The following is a description of a gene set: from publication Chen Y, Wang X (PMID 31504780) Human Gene Set: MIR561_3P studied in species Homo sapiens Genes predicted to be targets of miRBase v22 microRNA hsa-miR-561-3p in miRDB v6.0 with MirTarget v4 prediction scores > 80 (high confidence targets)., and this is the list of marker genes: BAIAP2, MGAT5, TVP23C, DNAJC7, NCL, NR1D2, EYA4, CPEB4, RNF141, SEPTIN7, C1QTNF3, DSG1, AMBN, ZNF471, CCL4, ZNF148, PIAS2, INO80D, UBE2K, SERINC5, PAK2, PEX5L, PRKRA, LRP12, ABHD13, DYRK4, LRRK2, EDIL3, PTGER3, REEP5, PSD3, PBX1 (PBX homeobox 1), FGF9, ARHGEF12 (Rho guanine nucleotide exchange factor 12), ECT2L, UBR3, STXBP5, MTMR7, KRR1, LMX1A, CGGBP1, GMCL1, APC, KRTAP4-7, RPS6KA6, VPS37A, ZBTB18, YPEL5, WDR43, GLS2, ZBTB1, ELAPOR2, SPAG9, SERF1A, TRIM2, DAZL, MYL12A, ARHGAP11A, TRUB1, PPM1N, HSD11B1, PCNX4, TLR2, PDSS1, DPY19L3, USP15, PRKD3 (protein kinase D3), NUCKS1, UNC119, TPM3, FZD1, SLC25A53, QKI, GADD45G, ADGRE2, VMP1, ZEB2, TEX14, ADGRL2, ADGRB3, SDC1, PBX3, RORA, UBE2W, MAML2, ZBTB21, PKD2 (NCBI Gene Id 5311), TENM4, OPRM1 (NCBI Gene Id 4988), LRRTM3, GRIA2, UBE2H, SLC18A2, SCAP, PRRG4, IRS2, KRTAP3-1, USP44, PHF6, TRIM13, MICU3, DNM3, STC1 (NCBI Gene Id 82914), CFAP61, SAMD12, PPA2, MARF1, WIPF3, DLGAP1, EPHA7, ZNF768, BCLAF3, GNPAT, SLC4A4, CAAP1, MOSPD1, CUL2, APOL6 (apolipoprotein L6), CLEC2B, QNG1, GPR63, ZNF816, PTPN21, EHBP1, HMG20A, PLAT, FAM124A, N4BP2L2, ATP8A1, TIGAR, RP2, FGF12, ABCA5, IWS1, NKX3-2, MIB1, ERV3-1, PCNX1, SLC45A4, MAGT1, DAZ2, PTPMT1, PCDH11X, ALG10B, PRPF40A, LRRC10, ARRDC3, IPCEF1, SOX2, SAMTOR, NIN, MAK16, NBN, ZBTB43, SETD9, ZNF280D, ARL8B, PPP4R2, SMARCA5, NETO2, ODF2L, KLF8, CORIN, RETREG1, CCL4L2, DDHD1, UFL1, GHR, HACD2, ACP3, CACNA1B, RO60, ATF7IP (NCBI Gene Id 55729), MBNL2, MZT1, ARMC3, ZFHX3, ZYG11B, CARF, MED14, C1orf21, CDH19 (cadherin 19), CNTN1, RFX3, GALNT2 (polypeptide N-acetylgalactosaminyltransferase 2), SFT2D1, CDK6, COL19A1, OMG, CEP55, TAF10, GTF2A1, PALS2, ZNF503, PLSCR3 (phospholipid scramblase 3), FOXO4, BRAP, ZFX, POLR2H, ZNF662, ALCAM, SGPP1, PHYHIPL, ROCK2, TVP23B, ZC3H12C, ARIH1, PAPOLG, LGSN, RANBP3, NUP160, ARPP19, NRK, EIF5A2, RIC8B, SLITRK4, HSPA13, SPRED1, USP9X, PRKAR1A, ZNF454, SLC25A15, GPR158, RFX7, RASAL2, TMF1, ZBTB44, ZNF99, ALOX12, XPOT, POPDC3, SLC36A4, STAC3, DAZAP1, EBF2, TXNDC12, ZDHHC20, SH2D3C, BIRC3, TWF1, POLR2E, RMND5A, TP53TG3D, RUVBL1, MR1, PRKAB2, MFAP3L, LRATD1, PRSS12, RRP15, MARS2, ACBD3, VAPA (NCBI Gene Id 9218), B3GALNT2, BCL11A, WDPCP, TRMT10A, FBXL3 (NCBI Gene Id 26224), WDFY3, NUDT21, ACAP2, PPP2CB, CNOT6L, DAZ1, BRWD3, PLPPR1, SOX5, KLHL24, ACVR2A, PTPN22, PCDH9, GPT2, S100A2, ROBO1, TP63, KLHL4, ZFHX4, KCTD3, SCYL2, NR2F2, CRIM1, CREB1, SNRPG, MAP3K21, NOTCH2, QRICH1, PCDHGA7, CASP1, CASK, PRDM8, CDYL2, SERPINH1, POU2F1, RBM6, UCHL3, SFRP2, ERCC6, RIOK3, H1-0, TNRC18, ATP11C, ACTR2, MKX, BCOR, SPEN, MARCHF5, FAM162B, PLK2, DNAI7, DIDO1, KHDRBS3, FNDC3A, ACVR2B, HDX, ANKRD13C, GRIA4, ECM2, FAM135A (NCBI Gene Id 80266), SON, TFDP1, NUFIP2, CTNNB1, BMAL2, KHSRP, NADK, PCDHB12, IFRD1, THEMIS, CRYBG3, FBXO22, CACNG7, SLC12A1, HOOK1, BRSK2, TMEM182, PNPLA8, SLC39A10, CRACDL, SDC2, SPRYD7 (SPRY domain containing 7), TENT4B, EIF4E3, ZFPM2, NLGN1, PAIP1, SLC44A1 (solute carrier family 44 member 1), MTMR6, CDCA4, HSPA1A, ARL5A, ZNF131, SOCS1, BCO1, MINDY2, BPNT2 (NCBI Gene Id 54928), BRD3, FYTTD1, MID1IP1, CPEB2, KRT10, BBS10, SETD1A, CHSY3, SNRPB2, ZBTB20, ID3 (NCBI Gene Id 3399), MBP, CUL3, SLTM, PHTF2, SERF1B, DCBLD2, GIT2, KLHL14, ZBTB6, DAZ3, DNAJC25, CDK14, SIX4, CCNH, NEK7, LCORL, ATXN3, HIPK1, MEGF10, ZFAND6, ZKSCAN7, TNS2, AGFG1, POMP, ZHX1, PIGW, ADAM10, CKAP2, CDKAL1, CCDC85A, PLXNC1, TMEM181, DACT1, TBX3, YLPM1, SLC35A1, ADAMTS6, IKZF2, MCOLN3, CCL28, GOLGA7, STAU1, PLCE1, SLC6A6, BPIFA3, CUL4B, GBP5, MATN3 (matrilin 3), ATG14, URI1, ZNF195, SPIRE1 (NCBI Gene Id 56907), RIMS2, CIT, VPS13C, RC3H1, PCDH17, TMEM59, RMI1, GATM, TNRC6B, C12orf71 (chromosome 12 open reading frame 71), DSP, LRATD2, NR0B1, ARPIN, TET2, PTPN2, MLLT1, DERA, PIP5K1A (phosphatidylinositol-4-phosphate 5-kinase type 1 alpha), NR4A2, ZNF770, DHX8, SORBS1, DAZ4, BTBD7, PCLO, ARHGAP29, RFXAP, DHODH, ZNF280C, HAPSTR1, SYT6, ANGPT2, ELAVL2, CEBPB, ZDHHC3, PARP4, TMED7, ELL2, HERC3, FBH1, CLDND1, SMAD3, FAM177A1, ZBTB8A, KIAA0232, TRMT5, FERMT2, ZFP28, MOCS2, MITD1, RRAGB, GOLIM4, GPR155, SLC4A7, SEC61B, XRN2, CCDC92, DENR, AHR (NCBI Gene Id 196), PDCL, UQCC1, KPNA4, HOXA5, ARHGAP5, STX17, TJP1, ATP6V0A2 (NCBI Gene Id 7854), ABHD18, SCAMP1, NUDT13, SYNJ1, TNFSF13B, C8orf82, ANKFY1, ZNF117, VSTM4, STK38L, PRKCB